The following is a description of a gene set: Human Gene Set: BOSCO_ALLERGEN_INDUCED_TH2_ASSOCIATED_MODULE Complex cellular functions within immunoinflammatory cascades are conducted by networks of interacting genes. In this study, we employed a network modeling approach to dissect and interpret global gene expression patterns in allergen-induced Th cell responses that underpin human atopic disease. We demonstrate that a subnet of interconnected genes enriched for Th2 and regulatory T cell-associated signatures plus many novel genes is hardwired into the atopic response and is a hallmark of atopy at the systems level. We show that activation of this subnet is stabilized via hyperconnected hub genes, the selective disruption of which can collapse the entire network in a comprehensive fashion. Finally, we investigated gene expression in different Th cell subsets and show that regulatory T cell- and Th2-associated signatures partition at different stages of Th memory cell differentiation. Moreover, we demonstrate the parallel presence of a core element of the Th2-associated gene signature in bystander naive cells, which can be reproduced by rIL-4. These findings indicate that network analysis provides significant additional insight into atopic mechanisms beyond that achievable with conventional microarray analyses, predicting functional interactions between novel genes and previously recognized members of the allergic cascade. This approach provides novel opportunities for design of therapeutic strategies that target entire networks of genes rather than individual effector molecules. species: Homo sapiens Genes representing a co-expression network in atopic CD4 T lymphocyte responses. from publication Bosco A, McKenna KL, Firth MJ, Sly PD, Holt PG (PMID 19414752), and this is the list of marker genes: TMEM71, IL5, HIPK2, FLT3LG, MAL, ITK, JCHAIN, CYTIP, ELL2, PLPP1, CCL1, HIPK1, FURIN, NAT9, SPINT2 (serine peptidase inhibitor, Kunitz type 2), GNPDA1, MIR4435-2HG, NR4A3, RASGRP3, CD69, TRAFD1, TAB2, YEATS4 (NCBI Gene Id 8089), IL4R, IL1B, SOCS1, TNFRSF9, RPL5, PECAM1, CDCA7L, DACT1, ELAPOR2, NDFIP2, OR5AN1, SERPINB6, PTGER2, CD200R1, FCER2, BHLHE40, LRFN2, POLR2M, CNKSR2, CEACAM1, PLCL1, APBB1IP, CYSLTR2, H4C14, STAP1, ISCA1, LIF, RASL11A, STK17B (serine/threonine kinase 17b), ALOX5, CLUHP3, RAB30, CES4A, IL13, CYSLTR1, LRRC32, ARRDC2, CASP3, IMMT, BTG1, EOMES, SEMA5A, DEPDC7, MEF2C, IRF4, CISH, FOXP3, STAT4 (NCBI Gene Id 6775), IL17RB, SOCS2, DPP4, ID2, BCL2L1, ETNK1, DCDC1 (doublecortin domain containing 1), TBC1D1, KPNA6, ASAP1, BCL6, SLC12A2, TIAM1 (TIAM Rac1 associated GEF 1), KLF3, NSMCE1, NCOA3, SEMA7A, RFLNB, IKZF4, RRAGD, IL2RA, SNTB1, NABP1, NFKBIZ, RRS1, SLC39A8, TSC22D3, RAP1A, BCL2 (BCL2 apoptosis regulator), PLXDC1, DHRS3, CDH1, IL36A, CAMK2D, CD84, HPGD (NCBI Gene Id 3248), CERS6, CYLD, TNFRSF14, CD83, IKZF1, XBP1, EEIG2, JAML, LRRN1, MKRN1, LCP2, RAB19, SLCO3A1, KRT1, CCL22, CXCL13, BATF, SLC37A3, SLC26A11, DARS1, DUSP5, MEOX1, CYTOR, PITRM1, SYTL3, SGSH, BCL9L, NRCAM, ENO1, PCGF5, PLLP, TAF4B, MIR155HG, TPP2, PGM1, CSF1, GFI1, TTC39B, MRPL35, RAB27B, PHF20L1, DUSP4, RAP2B